Given this list of marker genes SMARCC2, PRMT7, SLC35A2, RTL1, SUOX, NTNG2, TRAPPC11, AASS, PCDH19, ADGRG1, FGFR3, H4C5, POMT2, UNC80, ATRX, KDM6A, GLB1, SMS, COG5, SCN1B, RAC1, DPYD, SCN2A, CPE, SUCLG1, ASXL3, CDKL5, SCN1A, PIGO, NUP54, GLYCTK, UBA1, MT-ND5, ADNP, USP9X, MAF, MECP2, ALG11, EBF3, KIF15, GRM7, MYT1L (NCBI Gene Id 4662), NKX2-1, ZEB2, MT-TL1, ARX, SMC1A, MPDU1, MAN1B1, SCN9A, NODAL, CLTCL1, GRIN1, RPL10, PIGW, GAA, DPF2, SIK1, ATP6V0A2, TRPS1, TRIM8, DMXL2, MT-ND1, NEUROD2, PIGV, ATP6V1B2, SON, ERMARD, ARID1A, MT-ND6, GMPPB (GDP-mannose pyrophosphorylase B), SIM1, SARDH, CRIPTO, PGAP2, TGIF1 (NCBI Gene Id 91941), SIX3, DPAGT1, FGF8, DNMT3A, AHCY, SNRPN, CDC42, KCNA1, ADAR, PI4KA, PTCH1, TBCD, STAG2, PEX13, GATAD2B, TNNT1, FAT4, PLCH1, UGT1A1, STIL, SHH, H19, ATP10A, FOXH1, AFG2A, DLK1, MTRFR, TUBB2B, ITCH, GABRA1, GAMT, ACADS, ASAH1, GNAO1, DPM1, SYT1, NEU1, DLL1, ATP6V1A, KCNJ11, SLC25A22, GAS1 (NCBI Gene Id 2619), NACC1, NEK1, NAGS, MT-ND3, MOGS, CLCN4, SRD5A3, SMARCB1, PACS1, RAI1 (retinoic acid induced 1), LRP5, KCNH1, KCNN3, PIGQ, B4GALT1, SLC19A3, GABRG2, TBC1D24, MT-TW, OCA2, MEG3, SRPX2, GRIN2A, IGF2, ADAT3, MT-TK, SIAH1, SLC7A7, POGZ, GNB1, SMARCD1, GLI2, POMT1, UBE3A, GTPBP3, DOLK, PIGP, NALCN, PNKP, CDON, NUP62, DAG1, PIGY, ZIC2 (Zic family member 2), MT-ATP6, DEAF1, SOX4, COG8, UBTF, ACADVL, ATP6V1E1, FKRP, SATB2, MED12, ARID2, MAGEL2, SMARCE1, CASK, SMARCA4, PIGL (NCBI Gene Id 9487), WARS2, ARID1B, KMT2D, FGFR1, PGAP3, BMP2, COL5A1, SLC32A1, LARGE1, DISP1, MT-TV, DCHS1, TELO2, CWF19L1 (NCBI Gene Id 55280), MT-ND2, MT-ND4, SOX11, here is a description of the gene set: Floppy infant Floppiness/hypotonia is defined as reduced resistance to passive movement of joints. Physical examination of floppy/hypotonic infants shows head lag, lack of shoulder and elbow muscle contraction on traction response, inability to tighten the shoulder girdle muscles (or slipping through) when held under the axillae, scarf sign (when the arm is pulled to the opposite side, the arm wraps around the neck with the elbow crossing midline), hyperdorsiflexion of the feet, easy apposition of the thumb against the forearm, feet touching the cheek with ease and without discomfort, frog leg position, and inverted U sign on ventral suspension (head, arms, and legs hanging down without elbow or knee flexion and the trunk rounded in a dome shape). studied in species Homo sapiens Human Gene Set: HP_FLOPPY_INFANT